The following is a description of a gene set: Genes having at least one occurrence of the motif NKTSSCGC in the regions spanning 4 kb centered on their transcription starting sites. This matches the E2F1 transcription factor binding site V$E2F1_Q3 (v7.4 TRANSFAC). studied in species Homo sapiens Human Gene Set: E2F1_Q3, and this is the list of marker genes: STT3B (NCBI Gene Id 201595), UBR7, FLI1, ZNF827, NUTF2, LUC7L3, USP1, SYNGR4, TRIR, SOAT1, SLCO3A1 (NCBI Gene Id 28232), TENT5B (terminal nucleotidyltransferase 5B), CORT, BRME1, SYT6, ANKHD1-EIF4EBP3, MCM7, RTF1, CDC6, PHC1, RRM2, BRMS1L, YTHDC1, TMEM143, NDUFA11, HOXC10, H2AC12, MCM6, DNAJC9, SMAD6 (SMAD family member 6), ZCCHC8, TMPO, ZNF653, HMGN2, KIF15, FOXO3, EZH2, IPO7, SSBP3, CAND1, SNRPD1, KBTBD6, E2F7, RAVER1, MRPL18, SYT11, SUMO1, FMO4, POLE2, ZIM2, TMEM187, DNAJC5G, DLST, NCL, EHBP1, PELP1, LASP1, H2BC12, FAM216A, PODN, OTUD7B, ZNF644, FBXO5, TYRO3, EPHB2, RBL1 (RB transcriptional corepressor like 1), ATP1B4, CPNE5, SLC25A3, HCN3, SRSF7, MCM3, ZBTB8OS, ANAPC10, ID3, THAP8 (THAP domain containing 8), CASP8AP2, DCK, SNPH, TMEM255A, SHMT1, E2F1, SALL1, TFRC, DCTPP1, POLD1 (DNA polymerase delta 1, catalytic subunit), ANKHD1, RBBP4, PAQR4, SRSF1, HNRNPD, NFATC2IP, PHF12, SLITRK5, YBX2, GABRB3, CACNA1G, GON7, CDC25A, EMSY, HS6ST3, KIAA1143, PRPS1, TAOK2, KBTBD7 (kelch repeat and BTB domain containing 7), ASXL2, BARHL1, CDK1, PCNA, PDS5B, POLR1G, PAX6, KCNA6, EED, STAG2, DOLK, RPS6KA5, E2F8, GCH1, H2BC10, GPRC5B, MCM2, GINS3, ILF3, DNMT1, AK2 (adenylate kinase 2), PLK4, PAN2, OVOL2, PCSK4, PEG3, MSH2, HIRA, SP3, SMC3, ZNF565, AP4M1, PCSK1, HNRNPUL1, ARHGAP11A, PIAS1, TFAP4, H2AZ1, PIM1, FHOD1, SPTB, NUFIP2, ING3, STMN1, BAG6, POLE4, HNRNPR, TCP1, TRIM47, TBX6, ZNF687, USP37, ORC1, GRIA4, AP1S2, RABL6, CNOT9, ARID4A, FAM120C, IL4I1, MEIS1, MCMBP, GRIK2, PRPF38A, SERBP1, SMC6, CTDSPL2, GPN3, MYH10, NOLC1, MAML3, E2F3, ILF3-DT, UGGT1, ABCE1, MCM8, GPS2, ADCY8, NIPBL, GMNN, CNOT3, CLSPN, RMI2, POLR2A, NASP, GAPDH, KCNA1, ZNF524, CDC20B, PKMYT1, MXD3, SLC9A5, ASCL1, EIF4B, EPHB1, ATAD2, ATAD5, TRMT6, KLF5, ACBD6, ATE1, JADE2, ADAMTS2, TRIM39, NOL4, ZBTB4, NABP2, ZNF367, GSPT1 (NCBI Gene Id 2935), TIPIN, DMD, ATF5, RASAL2, POLD3, PPM1D, IRX3, TOPBP1 (NCBI Gene Id 11073), SASS6, SIX5, WDR62, CDCA7, ARHGAP6, ZNF362, MAZ, FIZ1, NUP62, H1-3, JADE1, APH1A, TRMT13, GEN1, PCLAF, POLA1, CCNT1, ALDH6A1, TBX3, STK35, IER5L, SMG1, NELL2, ABCF2, MTF2